The following is a description of a gene set: Mouse genes annotated to increased papilloma incidence (MP:0002014) retrieved from the Mouse Genome Informatics database via MouseMine species: Mus musculus from publication Motenko H, Neuhauser SB, O'Keefe M, Richardson JE (PMID 26092688) Mouse Gene Set: MP_INCREASED_PAPILLOMA_INCIDENCE, and this is the list of marker genes: Stag1, Ttc7, Hras, Fhit, Xpa, Fos, Klf10, Pdcd4, Mmp8, Rint1, Kit, Kras, Pten, Cdkn2a